The following is a description of a gene set: Any process that modulates the frequency, rate or extent of endopeptidase activity, the endohydrolysis of peptide bonds within proteins. Mouse Gene Set: GOBP_REGULATION_OF_ENDOPEPTIDASE_ACTIVITY species: Mus musculus, and this is the list of marker genes: Serpinb9f, Reck, Psma3, Lyn, Serpinb9e, Spink6, Tmed10, Serpinb6a, Gapdh-ps15, Serpinb9h, Gapdhrt, Serpinb1a, Psenen, Serpinb6b, Fetub, Aph1b, Vtn, Serpinb6e, Serpinb1b, Efna1, Serpinb9c, Furin, Serpinb13, Atp13a2, Serpinb9d, Akt1, Serpinb6d, Timp3, Serpinb6c, Serpinb9 (NCBI Gene Id 20723), Serpine1, Gapdhrt2, Stfa1, Stat3, Gapdh, Vsir, Ncstn, Spink2, Spock3, Psmb8, Mbp, Sfrp2, Spink1, Timp1, Efna3, Prelid1, Serpinb9b, Bin1, Ager, Serpinb1c, Aph1a, Stfa2, Rhbdf2, Serpinb8, Serpinb9g, Spock1, Aph1c, Nrdc, Crb2, Epha4